Given this list of marker genes Psmc1, Psma4, Psmb7, Tnks2, Psmd1, Psmd2, Psmb5, Psmd14, Tnks, Adrm1, Axin2, Psmd7, Psmb4, Axin1, Psmd11, Psmc2, Psmd3, Psma7, Psmd12, Psma3, Psma5, Psmb1, Ubb, Psma1, Psmc6, Smurf2, Psmd13, Psma2 (proteasome subunit alpha 2), Rps27a, Psmb6, Psmd8, Psmb2, Uba52, Psmc5, Psmc3, Psmc4, Psmb3, Psma6 (NCBI Gene Id 26443, proteasome subunit alpha 6), Ubc, Rnf146, Uba52rt, Psmd6, here is a description of the gene set: species: Mus musculus Degradation of AXIN Mouse Gene Set: REACTOME_DEGRADATION_OF_AXIN